Given this list of marker genes EYA3, SAMD4A, KLHL9, HNF4A, AR, ARL6IP5, DNA2, ESRRG, CRTC2, NAV2, CASC3, GATAD2B, SOHLH2, SEMA4G, ACKR2, SDK1, NGF, CD300LD-AS1 (NCBI Gene Id 146723), SKI, HOXC10, ULK1, KDM5C, PSD3, IMPDH1, NALF2, NDUFA10, METTL21A, ZFHX3, TRIM3, RASSF3, SNU13, NFIX, ELFN2, ZMYM3, SLC1A3, ABCG4, ADO, NECTIN1, LASP1, DLK1, REG1B, PCYT1A, HPCA, SOX12, PRRT2, ITGA8, FGF23, SGMS1, LRRTM1, KLHL13, NEMP2, KICS2, OXCT2, NSG2, CBX6, NFAM1, SRP54, PIANP, OPA3, UBE2W, YTHDC2, ADGRE5 (NCBI Gene Id 976), ZNF444 (NCBI Gene Id 55311), CCDC169-SOHLH2, RBM43, MYOM1 (NCBI Gene Id 8736), HNRNPA2B1, AHCY, AURKA, CS, LSAMP, NOVA2 (NCBI Gene Id 4859), ARHGEF9, NFAT5, JCAD, NISCH, KLK4, RNF103, BACE2, KLHDC10, CREB3L2, HERC3, CETP, DMBX1, GABBR2, TBC1D24, AIF1L, KSR2 (NCBI Gene Id 341537), HECTD4, BLTP3A, ISLR, WDTC1, CERS2, C20orf96, LSM8, IL2RG, PLXNA1, IGFBP4, TET3, CDC42EP4, PDLIM5, ANO6, UBE2D3, KCTD13, LRP2BP, WNT1, RND1, MAP3K9, SOX13, TP53INP1, CD44, HTT, PAX1, WNT9B, DTX1, SH3PXD2B, ADD2, FZD1, ADAMTS4, PHF8, POU2AF1, NCOR2, IL2RB, SEC31A, PTK2, BAK1, SHISA7, CDHR1, LENG8, UBE2O, SSH1, DLX3, PLAGL2, RAB3IL1, HSD17B13, ATP6V0D1, MEF2D, STK16, NDUFA4L2, MEIS3, SLC2A3, here is a description of the gene set: Human Gene Set: MIR4756_5P Genes predicted to be targets of miRBase v22 microRNA hsa-miR-4756-5p in miRDB v6.0 with MirTarget v4 prediction scores > 80 (high confidence targets). from publication Chen Y, Wang X (PMID 31504780) species: Homo sapiens